The following is a description of a gene set: species: Mus musculus The process in which the anatomical structures of the eye are generated and organized. The camera-type eye is an organ of sight that receives light through an aperture and focuses it through a lens, projecting it on a photoreceptor field. Mouse Gene Set: GOBP_CAMERA_TYPE_EYE_MORPHOGENESIS, and this is the list of marker genes: Nectin1, Mir96, Cnga3 (NCBI Gene Id 12790), Rdh13, Cfh, Sox9, Flt1, Thy1, Bbs10, Hmgn1 (high mobility group nucleosomal binding domain 1), Pde6c, Ptprm, Impg2 (NCBI Gene Id 224224), Cryaa, Fat1, Ihh, Yy1, Col8a2, Grk1 (G protein-coupled receptor kinase 1), Aqp5, Bhlhe23, Bhlhe22, Arid1a, Vsx1, Bbs4, Fat3, Tbx2, Tfap2b, Mir183, Casz1, Notch2, Th (tyrosine hydroxylase), Rp1, Notch1, Sox1, Irx6, Man2a1, Crb1 (NCBI Gene Id 338525), Grcc10 (NCBI Gene Id 80671), Scrib, Prdm1, Rom1, Twist1, Hipk2, Ahi1, Bax (NCBI Gene Id 12028), Tdrd7, Pitx3, Sox4, Thrb, Dio3, Rho, Slc1a1, Crygb, Aldh1a1, Sp3, Ptn (NCBI Gene Id 19242), Dll1, Sox12, Pax6, Rs1, Tbc1d20, Stat3, Trpm1, Aldh1a3, Sp1, Pitx2, Cntf, Vsx2, Gli3, Ikzf1, Nrl, Lctl, Crb2, Pou2f1, Tenm3, Mir124a-2, Kdm2b, Large1, Ift122, Nectin3, Nf1, Atp8a2, Mir124a-1, Bcar3, Jag1, Tsku, Meis1, Rpgr, Calb1, Lrp6, Mfsd2a, Cabp4, Rpgrip1l, Slc4a7, Tspan12, Atf4, Phactr4, Rbp4, Megf11, Ring1, Bak1, Cited2, Ndp, Ttc8, Fgfr3, Gnat1, Arl6, Col8a1, Aqp1, Tfap2a, Adamts9, Lrp5, Ntrk2, Ush1c, Sdk1, Epha2 (Eph receptor A2), Stra6, Sox2, Mir23a, Sox11, Dscam, Bmp4, Zeb1, Gdf11, Vegfa, Naglu, Samd7, Sdk2, Rpgrip1, Bmp7, Shroom2, Frs2, Abi2, Rorb, Foxe3 (forkhead box E3), Ptf1a, Alms1, Zhx2, Ephb1, Hif1a, Irx5, Fjx1, Ephb2, Gnat2, Ift172, Pax2, Vhl, Miat, Lhx1, Fzd5, Prom1 (NCBI Gene Id 19126), Foxn4, Mir182, Hcn1, Cdon, Kdr, Prox1, Hipk1, Mfn2, Foxf2, Ftx, Samd11, Ctnnb1, Six3, Vax2os (ventral anterior homeobox 2, opposite strand), Ski, Sox8